The following is a description of a gene set: Mouse Gene Set: GOBP_PEPTIDYL_TYROSINE_MODIFICATION The modification of peptidyl-tyrosine. species: Mus musculus, and this is the list of marker genes: Efna1, Cck, Gprc5a, Abi3, Mvp, Flt1, Clk1, Pecam1, Pxn, Erbb4, Tnfrsf14, Cd40, Ptger4, Ptpn4, Nod2, Kit, Cntf, Yes1, Dyrk3, Ctf1, Csf1r (colony stimulating factor 1 receptor), Ptpn2, Bmp6, Lck, Nox4, Lilra5, Aatk, Hsf1, Il11, Abl2, Il2, Rasa1 (RAS p21 protein activator 1), Epo, Sh2d1b2, Snhg20, Tnk2, Angpt4, Arrb2, Clk2, Itgb1, Tgfa, Fer, Jak1, Wee1, Dok7, Nedd9, Tnfsf18, Gata1, Ifnar1, Reln, Fgfr3, Il31ra (interleukin 31 receptor A), Il6st, Cav2, Egf, Vegfa, Pdgfa, Efna5, Cd80, Egfr, Unc119, Cblc, Clec7a, Zfyve28, Neurl1a, Csf3, Hax1, Ddr1, Ighm, Zgpat, Erbb2, Chmp6, Arl2bp, Slc35b3, Hes1, Pkdcc, Fgr, Ltk, Lrp4, Ins2 (insulin II), Ctnnd1, Pak2, Itgb3, Pibf1, Acvr1, Srcin1, Csf2, Ttk, Src, Cd4, Il6ra, Pdcl3, Errfi1, Gdnf, Ppp2r5b, Il12rb2, Jak2, Psen2, Dyrk1a, Flt4, Fgfr1, Il5, Areg, Lilrb4b, Osm, Hpx, Igf1, Kitl, Epha7, Fcer1a, Ptpn11, Cd74 (NCBI Gene Id 16149), Samsn1, Socs1, Dvl2, Traf3ip1, Ptprc, Slc35b2, Lilrb4a, Isl1, Epha3, Musk, Prkce, Nf2, Suz12, Socs4, Il9r, Btk, Ptk2, Dyrk2, Prkca, Il22ra2, Lonp1, Ntrk1, Ttbk1, Fyn, Clcf1, Itgb2l, Abi2, Gp6, Dmtn, Prkcz, Adnp, Abl1, Cadm4, Ptpn1, Tnfrsf18, Sh2d1b1, Ptk2b, Adam17, Ros1, Ptk6, Abi1 (NCBI Gene Id 214715), Aplp2, Parp9, Ggnbp2, Prnp, Adipoq, Ifng, Ptpn6, Fgf8, App (NCBI Gene Id 319425), Tgfb1, Crlf1, Zap70, Icam1, Insr, Stat5a, Pdgfra, Il18, Cd44, Inpp5f, Vps25, Tmem102, Lep, Vegfb, Psen1, Sfrp2, Il12b, Ccl5, Tspan9, Il22, Rap2c, Angpt1, Zzef1, Il13, Hcls1, Pdgfd, Il12rb1, Lrrk1, Ddr2, Socs3, Il3, Fgf10, Syk, Socs5, Ncl, Clk4, Mlst8, Fgfr2, Cd24a, Trem2, Itgb2, Clk3, Alk, Efemp1, Blk, Il15, Il12a (interleukin 12a), Igf1r, Tpst1, Mif, Pdgfb, Bank1, Tlr4, Grem1, Zfp592, Lif, Cntn1, Hdac2, Tek, Il7, Hnf4a, Cav1, Dgkq, Sfrp1, Il23a, Wnt3a, Htr2a, Il9, Il6 (interleukin 6), Epha1, Mtor, Ripk2, Rictor, Plpp3, Ptpn22, Fgf7, Pdgfc, Il24, Il34, Parp14, Thbs4, Bst1, Fes, Osbp, Lyn, Spink1, Tpst2, Mapk3, Iqgap1 (NCBI Gene Id 52178), Ephb2, Vtn, Fgfr4, Tnfrsf1a (NCBI Gene Id 21937), Arhgef2, Tsg101, Hck, Hyal2, Il4, Ehd4, Gprc5b, Hes5, Pdgfrb, Jak3, Cd3e, Nrg1, Itga5, Ptprz1, Tnf, Rap2b, Srms, Irf1, Prlr, Cnot7, Dusp22, Epha4, Agrn, Hbegf, Gfra1, Hrg, Cspg4, Kdr, Il21, Ntf3, Fbxw7 (F-box and WD-40 domain protein 7), Cass4, Agt, Enpp2 (NCBI Gene Id 223584)